Given this list of marker genes Hint1, Tcf7l1, Tcf7, Sin3a, Ctnnb1, Tcf7l2, here is a description of the gene set: part of: MITF-M-dependent gene expression electronically inferred by orthology from the curated human pathway Reactome Pathway: Regulation of MITF-M-dependent genes involved in cell cycle and proliferation species: Mus musculus This event has been computationally inferred from an event that has been demonstrated in another species.<p>The inference is based on the homology mapping from PANTHER. Briefly, reactions for which all involved PhysicalEntities (in input, output and catalyst) have a mapped orthologue/paralogue (for complexes at least 75% of components must have a mapping) are inferred to the other species.